Given this list of marker genes SMC1A, PDS5B, MAU2, RAD21, STAG1, KIF20A, SMC3, PLK1, STAG2, KIF23, NIPBL, PDS5A, WAPL, here is a description of the gene set: species: Homo sapiens Mitotic Telophase/Cytokinesis Human Gene Set: REACTOME_MITOTIC_TELOPHASE_CYTOKINESIS